The following is a description of a gene set: Toe clinodactyly Bending or curvature of a toe in the tibial direction (i.e., towards the big toe). studied in species Homo sapiens Human Gene Set: HP_TOE_CLINODACTYLY, and this is the list of marker genes: TGFBR2, SATB2, DACT1, NOG, WWOX, CKAP2L (NCBI Gene Id 150468), RFX7, ATP2B1, FRA10AC1, RAB3GAP2, HEPHL1, DLEC1, TAF4, RNF6, COG8, EZH2, FLI1, RSPRY1, SALL1, PIGH, KCNJ5, HNRNPR, ALG3 (NCBI Gene Id 131416), FLNA, XYLT1, KCNJ2